The following is a description of a gene set: Mouse Gene Set: MIKKELSEN_IPS_WITH_HCP_H3K27ME3 Genes with high-CpG-density promoters (HCP) bearing the tri-methylation mark at H3K27 (H3K27me3) in MCV8.1 (induced pluripotent cells, iPS). Somatic cells can be reprogrammed to a pluripotent state through the ectopic expression of defined transcription factors. Understanding the mechanism and kinetics of this transformation may shed light on the nature of developmental potency and suggest strategies with improved efficiency or safety. Here we report an integrative genomic analysis of reprogramming of mouse fibroblasts and B lymphocytes. Lineage-committed cells show a complex response to the ectopic expression involving induction of genes downstream of individual reprogramming factors. Fully reprogrammed cells show gene expression and epigenetic states that are highly similar to embryonic stem cells. In contrast, stable partially reprogrammed cell lines show reactivation of a distinctive subset of stem-cell-related genes, incomplete repression of lineage-specifying transcription factors, and DNA hypermethylation at pluripotency-related loci. These observations suggest that some cells may become trapped in partially reprogrammed states owing to incomplete repression of transcription factors, and that DNA de-methylation is an inefficient step in the transition to pluripotency. We demonstrate that RNA inhibition of transcription factors can facilitate reprogramming, and that treatment with DNA methyltransferase inhibitors can improve the overall efficiency of the reprogramming process. studied in species Mus musculus from publication Mikkelsen TS, Hanna J, Zhang X, Ku M, Wernig M, Schorderet P, Bernstein BE, Jaenisch R, Lander ES, Meissner A (PMID 18509334), and this is the list of marker genes: Igf2, Vsnl1, Tbx4, Evx2, Arx, Slitrk3, Six3, Tmem59l, Prrt1, Tfap2b, Slc6a4, Npy5r, Pcdhb15, Hoxc8, Pcdhb17, Hoxb3, Hoxa3, Hoxc6, Pcdha12, Tmem174, Mpped1, Hbq1b, Pcdha9, Car10, Npas4, Fgf12, Hoxb7, Uncx, Tfap2d, Avp, Hoxd4 (homeobox D4), Ache, Pyy, Kcnk9, Osr1, Lrrk2, Prdm13, Nalf1, Crlf1, Usp18, Elovl3, Hpse2, Asic2, Otp, Alox15, Mycbp2, Hoxb6, Slc25a31, Wnt1, Lbx1, Hba-x, Hoxc9, Tex12, Cacng2, Otop3, Htr2c, Phox2b (NCBI Gene Id 245706), Pappa, Adgrl3, Gfi1, Wnt10a, Hoxd10, Hoxb8, Grm8, Kcns1, Taf7l, Duoxa2, Nr2f2, Actl6b, Cdh11, Hoxb1, Nr2e1, Hoxc10, Ntm, Zfp536, Lhx9, Dbx1, Nrn1, Pcdha11, Sorcs3, Ereg, Ush1g (USH1 protein network component sans), Hoxa2, Kcnip1, Cacna1e, Calb1, Nfix, Rph3a, Pcdha4, Tdrd1, Foxl1, Cacna1g, Insrr, Hoxb5, Duox2, Tbx5, Hoxa11, Pcdha2, Il10ra, Prdm8, Pcdh11x, Hoxb2, Zmynd10